Given this list of marker genes Cxcr2, Selenos, Itgam, Fas, Pik3cb, Pik3cd, Fasl, Slc7a11, Mef2c, Cdkn2a, Fcgr2b, Ccr5, Il18, Gm14461, Il6, Hcar2, Hmga1, Nod2, St6gal1, Ccl5, Zmpste24, Ifng, Cd44, Plekho2, Ghsr, Anxa1, Sirt1, Pten, Itpkb, here is a description of the gene set: Any apoptotic process in an inflammatory cell, any cell participating in the inflammatory response to a foreign substance e.g. neutrophil, macrophage. species: Mus musculus Mouse Gene Set: GOBP_INFLAMMATORY_CELL_APOPTOTIC_PROCESS